Given this list of marker genes PPP1R9B, FILIP1L, CTTNBP2NL, LUZP1, FILIP1, here is a description of the gene set: species: Homo sapiens Human Gene Set: GOBP_PROTEIN_LOCALIZATION_TO_ACTIN_CYTOSKELETON A process in which a protein is transported to, or maintained in, the location of an actin cytoskeleton.